The following is a description of a gene set: from publication Lee CK, Weindruch R, Prolla TA (PMID 10888876) Ageing of the brain leads to impairments in cognitive and motor skills, and is the major risk factor for several common neurological disorders such as Alzheimer disease (AD) and Parkinson disease (PD). Recent studies suggest that normal brain ageing is associated with subtle morphological and functional alterations in specific neuronal circuits, as opposed to large-scale neuronal loss. In fact, ageing of the central nervous system in diverse mammalian species shares many features, such as atrophy of pyramidal neurons, synaptic atrophy, decrease of striatal dopamine receptors, accumulation of fluorescent pigments, cytoskeletal abnormalities, and reactive astrocytes and microglia. To provide the first global analysis of brain ageing at the molecular level, we used oligonucleotide arrays representing genes to determine the gene-expression profile of the ageing neocortex and cerebellum in mice. Ageing resulted in a gene-expression profile indicative of an inflammatory response, oxidative stress and reduced neurotrophic support in both brain regions. At the transcriptional level, brain ageing in mice displays parallels with human neurodegenerative disorders. Caloric restriction, which retards the ageing process in mammals, selectively attenuated the age-associated induction of genes encoding inflammatory and stress responses. Down-regulated in the neocortex of aged (30-month) mice subjected to caloric restriction since young adulthood. species: Mus musculus Human Gene Set: LEE_CALORIE_RESTRICTION_NEOCORTEX_DN, and this is the list of marker genes: EEF1D, NEUROG1, KIF5B, POLR2G, ATP5PB, BUB3, PGK2, ACLY, MDK, EIF4A1, IARS1, NFE2L2 (NFE2 like bZIP transcription factor 2), H1-2, ITGB4, ZYX, EEF2, IL17A, GNG2, FOXN1, SKP1, XPC, DDR2, FZD5, FUT4, CHRM4, DUSP7, IFNA21, CALM3, CDK4, IRS3P, RAC1, RELA (NCBI Gene Id 5970), CACNB2, SERPINA6, GNG12, GALT, C19orf53, CYP19A1, PRPF6, SEC23A, PML, APOB, TOP3B, CYP3A5 (NCBI Gene Id 1577), RAP2B, EDN1, EIF2S1, APOC4, CCL2, ALOX5AP, ZBTB16, USP9X (ubiquitin specific peptidase 9 X-linked), CNTN3, PTPN14, COL4A1, IHH, KCNH1, GRIN1 (glutamate ionotropic receptor NMDA type subunit 1), EPRS1, TFRC, PHKG2, ATP2A2, RBM4, H2AX, KIF20A, SLC6A8, MSH3, LMNB2, CHKA (choline kinase alpha)